The following is a description of a gene set: Human Gene Set: HP_PREMATURE_PUBARCHE studied in species Homo sapiens Premature pubarche The onset of growth of pubic hair at an earlier age than normal., and this is the list of marker genes: CYP11B1, NDN, HSD11B1, PAPSS2, SIM1, SNRPN, MKRN3, HSD3B2, MAGEL2, AIP, MEN1, OCA2, TANGO2